The following is a description of a gene set: Human Gene Set: GAO_LARGE_INTESTINE_24W_C10_ENTEROCYTE from publication Gao S, Yan L, Wang R, Li J, Yong J, Zhou X, Wei Y, Wu X, Wang X, Fan X, Yan J, Zhi X, Gao Y, Guo H, Jin X, Wang W, Mao Y, Wang F, Wen L, Fu W, Ge H, Qiao J, Tang F (PMID 29802404) species: Homo sapiens, and this is the list of marker genes: ANPEP, CDHR5, STEAP1, IGF2BP2, CLDN23, CA7, MUC20, MCF2L2 (NCBI Gene Id 23101), GPANK1, SLC35D2, PRAP1, MAMDC4, ZNF264, MALL, NR1H4, EPCIP, TMEM45B, LYPD8 (LY6/PLAUR domain containing 8), MSLN, MLXIPL, GUCA2B, RNPC3, PRSS3 (serine protease 3), GSTA1, MYO1A, CYP2W1, MOGAT2, PLS1, LRRC57, CYP3A5, SLC41A2, TONSL, KCNJ5, HTATIP2, EFNA2, NBEAL1, LAD1, SPIB, LPAR5, PARP12, SLC15A1 (solute carrier family 15 member 1), SLC13A1, GUCA2A, EPS8L3, SLC6A19, SMIM24, CNKSR1, RARRES1 (NCBI Gene Id 5918), AQP8, AOC1, DGAT1, SI, CEACAM7 (NCBI Gene Id 1087), NR1I2, DPEP1, NOXA1